The following is a description of a gene set: species: Mus musculus Any process that modulates the frequency, rate or extent of action potential creation, propagation or termination in a cardiac muscle cell. This typically occurs via modulation of the activity or expression of voltage-gated ion channels. Mouse Gene Set: GOBP_REGULATION_OF_CARDIAC_MUSCLE_CELL_ACTION_POTENTIAL, and this is the list of marker genes: Dlg1, Dsg2, Jup, Bin1, Cav1, Fgf13, Cxadr, Slc4a3, Trpm4, Gja5, Rangrf, Ctnna3, Camk2d, Cacna1c, Tmem161b, Tbx18, Pkp2, Ank2, Calm2, Calm1, Dsc2, Cav3, Calm3, Dsp, Ryr2, Atp2a2, Hcn4, Akap9